The following is a description of a gene set: studied in species Homo sapiens The series of events required for an organism to receive a temperature stimulus, convert it to a molecular signal, and recognize and characterize the signal. Thermoception in larger animals is mainly done in the skin; mammals have at least two types of sensor, for detecting heat (temperatures above body temperature) and cold (temperatures below body temperature). Human Gene Set: GOBP_THERMOCEPTION, and this is the list of marker genes: GRIK2, RHO, OPN4, WDR47, TRPM8, TRPV1, ADRA2A, TRPA1